Given this list of marker genes Snca, Faap24, Mapt, Ilf2, Tuba1a, Sphk1, Isg15, Map2k6, Dhx9, Ptpn2, Dnajc3, Tubb2b, Ppp2r1a, Ppp2ca, Tubb4a, Fancf, Ppp2r5a, Mavs, Trp53, Tubb3, Tuba3b, Tuba1c, Ikbkb, Hspa8, Hspa1a, Tubb2a, Tuba4a, Cenps, Dus2, Tubb1, Fancm, Prkra, Tuba8, Hspa2, Fanca, Hspa1l, Fancl, Chuk, Arih1, Fancg, Tuba1b, Cenpx, Stat3, Faap100, Adar, Tubb6, Tuba3a, Hspa1b, Trim25, Ube2l6, Faap20, Cdk1, Ikbkg, Nck1, Npm1, Fancb, Tubal3, Ppp2cb, Ilf3, Fancc, Fance (NCBI Gene Id 72775), Ppp2r1b, Tarbp2 (NCBI Gene Id 21357), Eif2ak2, Tubb4b, here is a description of the gene set: PKR-mediated signaling studied in species Mus musculus Mouse Gene Set: REACTOME_PKR_MEDIATED_SIGNALING